Given this list of marker genes Slc9a1, Slc9a5, Tmco3, Slc9a7, Slc9a3, Slc17a6, Slc17a7, Slc9c1, Slc9a6, Slc9a2, Slc9a4, Slc9a8, Slc9a9 (solute carrier family 9 (sodium/hydrogen exchanger), member 9), here is a description of the gene set: Enables the transfer of a solute or solutes from one side of a membrane to the other according to the reaction: K+(in) + H+(out) = K+(out) + H+(in). Mouse Gene Set: GOMF_POTASSIUM_PROTON_ANTIPORTER_ACTIVITY species: Mus musculus